The following is a description of a gene set: from publication Chen Y, Wang X (PMID 31504780) Human Gene Set: MIR1203 Genes predicted to be targets of miRBase v22 microRNA hsa-miR-1203 in miRDB v6.0 with MirTarget v4 prediction scores > 80 (high confidence targets). studied in species Homo sapiens, and this is the list of marker genes: SOX12, MCTS1, TOMM40L, TMEM184C, GLI2